Given this list of marker genes Ran, Rab40b, Fgd2, Rras, Arfgap3, Arhgap35, Rpgr, Srp54a, Tbc1d2, Sos1, Chml, Rab2a, Dennd11, Rasef (RAS and EF hand domain containing), Gpn2, Abce1, Asap1, Rapgef6, Vav1, Mmut, Myo9a, Smcr8, Eif2b1, Arl2, Rgs10, Prr5, Rab18, Rras2, Arhgef6, Rabl2, Rhod, Sec23a, Rhoc, Zng1, Dock11, Gimap7 (GTPase, IMAP family member 7), Cpeb2, Asap2, Tbc1d4, Rab28, Arhgap18, Ngef, Rap1gds1, Ralgapb, Nras, Rab37, Ralb, Rab39, Rab4b, Nuggc, C9orf72, Gnai3, Arl8a, Arhgef39, Rab24, Farp2, Septin6, Rgs11, Nucb2, Arhgap25, Rhog, Arhgef25, Tppp, Rgl3, Als2, Rerg, Mx2, Diras1, Rgs3, Ophn1, Kndc1, Gbp2, Dock4, Cracr2a, Arhgap5, Lamtor2, Gspt2, Rcc1l (NCBI Gene Id 94254), Rasgef1b, Iqsec1, Rab22a, Tbc1d16, Arhgap23, Arf3, Fam13b, Arl14, Rab20, Rgp1 (NCBI Gene Id 68706), Bcr, Tbcc, Rab7, Ralgps1, Gnai1, Tubb2b, Rab3ip, Tbc1d10c, Iqsec2, Rabgap1l, Rasgrp3, Abr, Rin2, Arl13a, Eif2s3y, Wdr41, Psd2, Septin8, Septin2, Septin14, Sipa1l1, Rab11a, Dnaja3, Dennd10, Tbcd, Nrp1 (NCBI Gene Id 270112), Sh3bp5, Arhgdia, Gbp6, Arf1, Gfm2, Slit2 (NCBI Gene Id 338531), Dnmbp, Gna13, Arhgap44, Fbxo8 (NCBI Gene Id 50753), Arap1, Dennd2a, Tbc1d13, Tubb1, Rasgrp1, Psd3, Rasgrp4, Spata13, Rnd2 (Rho family GTPase 2), Rab21, Usp6nl, Gnat3, Rab7b, Sipa1l2, Dennd1a, Arhgap20, Syde1, Nf1, Sergef, Rem1, Tbc1d1, Thg1l, Rinl, Cdc42ep2, Rasgrf1, Rac2, Arhgap42, Gbp2b, Rab19, Eftud2, Nucb1, Lamtor3, Rab13, Ric8b, Plcb1, Rab3gap1, Rab8b, Rasal1, Srgap1, Arhgef28, Wnt11, Gnb5, Eif5, Rgs8, Dennd1b, Rcc1, Tgtp1, Rab9, Chn2, Rab27a, Rab3il1, Ralgps2, Gbp9, Sipa1l3, Acap2, Plekhg1, Guf1, Tiam1, Ranbp2, Madd, Iqgap3, Rabgef1, Mx1, Ranbp10 (RAN binding protein 10), Dnm3, Chm, Arhgef4, Egf, Chrm4, Arap3, Eef2, Sar1b, Tbc1d24, Prex1, Bms1, Depdc1b, Tiam2, Arhgap17, Eef1a2, Rab9b, Elmod3, Obscn, Drg2, Hmgcr, Stxbp5, Dennd5b, Arhgef11, Sipa1, Rabep1, Rgs7, Rasa2, Arhgef10, Rcc2, Stard13, Fgd1, Rnf112, Rit1 (NCBI Gene Id 19769), Syde2, Rraga, Arf2, Gnaq, Fgd4, Arl2bp, Dennd2c, Dennd6a, Hras, Thy1, Arhgap15, Gm4841, Rasl2-9, Arhgef9, Ect2, Rabgap1, Srp54b, Rab12, Gnai2, Mcf2, Atl2, Trio, Gnat2, Tufm, Tubb5, Dgki, 9930111J21Rik1, Arhgef10l (NCBI Gene Id 72754), Rab6a, Kalrn, Sh3bp5l, Rap2c, Rhot2, Rragd, Gbp7, Eps8l2, Rhob, Ralgapa1, Rgs16, Rgs20, Arhgap29, Gbp3, Septin3, Lsg1, Rhebl1, Arl6, Rab3gap2, Pgam5, Gpn1, Evi5l, Arf5, Rab5b, Rhou, Ccz1, Tbc1d5, Diras2, Mfn2, Elmod2, Gna11, Elmo1, Tagap, Entpd1, Kras, Rasgrp2, Gna14, Gm266, Agap3, Arl3 (ADP-ribosylation factor-like 3), Rab1b, Evi5, Arhgap1, Arrb1, Agfg1, Tubb3, Fgd5, Gdpgp1, Tuba1b (NCBI Gene Id 22143), Rasa1, Septin12, Rab14, Smap1, Gnaz, Itgb1bp1, Mfn1, Dennd5a, Tbc1d30, Rhobtb1, Itsn1, Gtpbp10, Git2, Racgap1, Stxbp5l, Gbp5, Lamtor5 (late endosomal/lysosomal adaptor, MAPK and MTOR activator 5), Rab26, Plekhg3, Arl8b, Sirpa, Rab35, Tubb6, Rap1b, Mmaa, Pde6d, Rab3b, Srgap2, Grb2, Gngt1, Itsn2, Eef1d, Flcn, Plce1, Ankrd27, Sgsm3, Rnd3, Dnm2, Rrad, Chn1, Arhgef33, Septin4, Arhgap12, Arhgap9, Iigp1c, Dock9, Arhgef38, Rasal3, Gbf1, Rem2, Llgl2, Gnao1, Acap1, Arhgap28, Arhgap21, Git1, Rab33a, Eif2s3x, Rgs5, Gbp4, Dennd4a, Rasgef1a, Dennd2d, Arhgef15, Tbc1d17, Rasa4, Gnl1, Rab3c, Mycbp2, Nkiras1, Arl5a, Gpsm3, Arhgef19, Psd4, Nkiras2, Iqsec3, Rab38, Dab2ip, Als2cl, Tubb4b, Arl1, Tbc1d10b, Agap1, Rab29, Rhof, Arhgdig, Krit1, Rac3 (NCBI Gene Id 170758), Garnl3, Arhgap19, Igtp, Ccdc88c (NCBI Gene Id 68339), Lars1, Rab1a, Rhot1, Tbc1d22b, Fgd3, Rab2b, Gm5431, Depdc1a, Gng4, Depdc5, Net1, Arhgef2, Septin10, Rab34, Dennd2b, Acap3, 1700009N14Rik, Rab5a (RAB5A, member RAS oncogene family), Gdi1, Ift27, Rap1a, Adap2, Rab8a, Rab42, Nprl3, Rap1gap2, Gapvd1, Cplane2, Irgc, Sbf2, Sec23b, Plcd4, Gbp10, Preb, Rgs1, Arf4, Arhgap10, Cyth2, Dnajc27, Dock3, Sh3bp4, Ifi47, Arhgap40, Gbp8, Fgd6, Slc38a9 (solute carrier family 38, member 9), Rab31, Rab44, Rragc, Gm1527, 1700006A11Rik, Arhgap32, Gopc, Gnb1, Mtss2, Arhgap27, Tns3, Rapgefl1, Agfg2, Rheb, Gna15 (guanine nucleotide binding protein, alpha 15), Rhoq, Dock5, Bcar3, Rapgef1 (Rap guanine nucleotide exchange factor (GEF) 1), Arhgap33, Mras, Gem, Rasgef1c, Sgsm2, Plekhg5, Rab10, Rac1, Myo9b, Cyth3, Plekhg6, Mtif2 (mitochondrial translational initiation factor 2), Arhgap6, Rab36, Gnat1, Rab17, Rgs4, Arhgap11a, Ralgapa2, Atl1, Arhgef1, Rapgef5, Hps1, Dock8, Rhobtb3, Gtpbp3, Gngt2, Drg1, Gpsm1, Ntpcr, Gng3 (NCBI Gene Id 14704), Hbs1l, Adap1, Arhgap22, Cyth4, Gm12185, Rab15, Gna12, Vav3, Tbc1d20, Efl1, Eps8l3, Rabep2, Rasd1, Vps9d1, Dennd4b, Tbc1d2b, Arhgef7, Septin9, Rap1gap, Gtpbp2, Abca4, Arhgap39, Plekhg2, Rangrf, Gnas, Sh2d3c, Tbc1d7, Tbc1d25, Ccdc88a, Rtkn, Jun, Gm12250, Tbc1d8, Septin1, Mcf2l, Rabif, Gipc1, Arl4c, Rasd2, Dock7, Ric8a, Rab39b, Rgs2 (NCBI Gene Id 19735), Farp1, Sar1a, Rhoh, Rab40c, Gripap1, Cyth1, Atl3, Elmod1, Mon1a, Ralbp1, Rp2, Nlrp10, Tsr1, Dock2, Gfm1, Cavin4, Tbc1d9b, Mtg2, Arl13b, Arhgef12, Asap3, Iigp1, Dennd6b, Rab4a, Gspt1, Tbc1d22a, Arl11, Rasl11b, Arhgap30, Gtpbp4, Eif2b4, Irgq, Dis3, Srpra, Irgm1, Eif2b2, Eefsec, Gng2, Rasl10a, Arfgap2, Hps4, Rgl1, Arhgap45, Arl4a, Rhoj, Cdc42, Arhgef37, Eef1a1, Rab11b, Arhgap8, Rab5c, Grtp1, Rasa3, Htr2b (5-hydroxytryptamine (serotonin) receptor 2B), Rab32, Dennd3, Ranbp1, Stard8, Tbc1d21, Eif2b5, Vav2, Ddx3x (DEAD box helicase 3, X-linked), Arhgef17, Gdi2, Eif2b3, Gnb3, Arhgdib, Tgtp2, Sh3bp1, Gpsm2, Arl5c, Plcg1, Rapgef2, Gnal, Tbc1d8b, Rangap1, Rragb (NCBI Gene Id 406229), Arf6, Arhgap24, Syngap1, Agap2, Rgs6, Rnd1, Rgs17, Tbc1d10a, Sos2, Lamtor4, Adss1, Gtpbp1, Akap13, Arfgef3 (NCBI Gene Id 52870), Tubb2a, Nckap1l, Tbc1d15, Rab3a, Rhobtb2 (NCBI Gene Id 78731), Eps8l1, Gpn3, Dock10, Arap2, Arl15, Rab6b, Nprl2, F830016B08Rik, Lrrk2, Llgl1, Arhgap36, Iqgap1, Irgm2, Arl5b, Ngb, Rab30, Arhgef3, Tbc1d9, Adgrb3, Deptor, Arfrp1, Rhov, Arhgap4, D1Pas1, Anxa7 (NCBI Gene Id 11750), Gch1, Rapgef4, Rgl2, Dennd4c, Rin3, Dock1, Ralgds, Arl4d, Arfgap1, Srgap3, Tbck, Rasl12, Lamtor1, Arfgef1, Rgs14, Rasl11a, Tbc1d14, Frmd7, Entpd7, Gnb2, Arl10, Arhgap26, Septin7, Smap2, Arhgef40, Arhgef18, Rab3d, 4930544G11Rik, Rgs9, Rab25, Arfgef2, Eif5b, Rab23, Septin5, Arhgef16, Dnm1l, Sgsm1, Rap2a, Septin11, Rala, Rabl3 (NCBI Gene Id 67657), Dnm1, Rin1, Gnb4, Rab27b, Rab33b, Gmip (Gem-interacting protein), Tubb4a, Eras, Rasl10b, Tbc1d12, Arhgef5, Eef1b2, Rgs18, Arhgap31, Dock6, Trim23, Mtg1, Prex2, Rap2b, Rgs12, Dennd1c, Rit2, Ocrl, Iqgap2, Tsc2, Sec61b, Psd, Rab43, Pcp2, Rhoa, Ric1, Ift22, Rasgrf2, Dlc1, Sbf1, Sesn2, Opa1, Srp54c, Rapgef3, here is a description of the gene set: Mouse Gene Set: GOMF_GTPASE_ACTIVITY species: Mus musculus Catalysis of the reaction: GTP + H2O = GDP + H+ + phosphate.